Given this list of marker genes IL23R, C4A, CCR1, IL12A-AS1, TLR4, FAS, IFNGR1 (NCBI Gene Id 3459), UBAC2, IL12A, IL10 (NCBI Gene Id 3586), STAT4, TNFRSF1A, MEFV, ERAP1, KLRC4, HLA-B, here is a description of the gene set: studied in species Homo sapiens Testicular inflammation. Orchitis Human Gene Set: HP_ORCHITIS